Given this list of marker genes ZNF714, SLC29A3, RASSF2, SLC9A2, EPHB1, TEF, FMNL2, CDC7, PCLO, ZNF138, ZNF117, VPS35, RTN4RL2, TMEM109, TC2N, FKBP1A, GAS7, RAP1A, TAB2, FUT1, GALM, FREM2, UBR1, DDX6, NKAIN2, SPAG11B, BTG1, TNRC6B, RBSN, BNC2, CXADR, PCF11, CLPTM1, RBM27 (NCBI Gene Id 54439), NKPD1, CERS6, SOX6, UBE2D2, TACC1, SERINC3, TP53TG3B, EIF3J, ADGRG7, HSPA1A, ANKRD37, ZNF765, OLAH, BOD1L2, SLC25A36, ZNF676, TAF1D, SEMA4D, QTRT2, POU3F3, LHFPL2, C4orf3, EPHA3, AKAP8, H3-5, CNOT2, NR2C1, DAG1, LRRC7, ARK2C, COX15, LYPD6B, TECRL, ARMCX3, WDTC1, ZNF99 (NCBI Gene Id 7652), NDUFA8, MEF2A, MAPK14, TFF3, PKP4, THAP12, DCAF4L2, PIM2, CALCR, ZNF486, RELCH, CDH10, BOD1, ASF1A, COL25A1, NKIRAS2, PLCE1, TP53TG3C, ZNF621, CLTC, TMEM70, WDR26, C15orf40, ZNF813, ATP5F1E, CFAP61, QKI, TP53TG3, BOK (NCBI Gene Id 84558), N4BP1, IL17RD, here is a description of the gene set: from publication Chen Y, Wang X (PMID 31504780) Genes predicted to be targets of miRBase v22 microRNA hsa-miR-6754-3p in miRDB v6.0 with MirTarget v4 prediction scores > 80 (high confidence targets). studied in species Homo sapiens Human Gene Set: MIR6754_3P